The following is a description of a gene set: Reactome Pathway: Defective PNP disrupts phosphorolysis of (deoxy)guanosine and (deoxy)inosine Normally in humans, PNP (purine nucleotide phosphorylase) catalyzes the conversion of (deoxy)guanosine and (deoxy)inosine to guanine and hypoxanthine, respectively. In the absence of PNP activity, however, these purine nucleosides accumulate, disrupting lymphoid cell function and leading to severe immunodeficiency. part of: Nucleotide catabolism defects studied in species Homo sapiens, and this is the list of marker genes: PNP